Given this list of marker genes DBN1, COPS4, ROCK2, CUL3, TRA2B, SRRM1, PDE5A, CCT2, COPS2, MYO6, RNF20, CPSF7, VIM, ROCK1, CCT7, TXNL1, GPS1, HNRNPC, SPEN, RBBP6, RBMX, RHOBTB1, STK38, here is a description of the gene set: Reactome Pathway: RHOBTB1 GTPase cycle RHOBTB1 is an atypical member of the RHO GTPase family that is predicted not to cycle between a GTP-bound form and a GDP-bound form. RHOBTB family proteins, in contrast to other RHO GTPases, possess other conserved domains in addition to the GTPase domain. The GTPase domain at the N-terminus is followed by a proline-rich region, a tandem of two BTB (broad-complex, tramtrack, bric à brac) domains, and a conserved C-terminal BACK (BTB and C-terminal Kelch) domain. RHOBTB proteins can form homo- and heterodimers, but the role of dimerization in RHOBTB function is not known. RHOBTB1 is highly expressed in skeletal muscle, placenta, stomach, kidney, testis, ovary, uterus and adrenal gland. RHOBTB1 is a component of a signaling cascade that regulates vascular function and blood pressure. RHOBTB1 level is decreased in many cancer types and it is proposed to function as a tumor suppressor, but no mutations in RHOBTB1 have been detected in cancer. RHOBTB1 localizes at early endosomes and participates in the architecture of the endosomal-lysosomal system. part of: RHOBTB GTPase Cycle studied in species Homo sapiens